Given this list of marker genes MAP3K10, MTCO3P12, MIR6810, INTS12, DSTYK, LINC01596, RBBP5, MT-TE, MTND5P11, ING4, GSTCD, POLD1, KLHDC9, MT-TT, GTPBP3, MT-ND6, RPL37, ANO8, here is a description of the gene set: species: Homo sapiens from publication Yevshin I, Sharipov R, Kolmykov S, Kondrakhin Y, Kolpakov F (PMID 30445619) Human Gene Set: ZNF454_TARGET_GENES Genes containing one or more binding sites for (ZNF454) in their promoter regions (TSS -1000,+100 bp) as identified by GTRD version 20.06 ChIP-seq harmonization.